Given this list of marker genes RAB11FIP3, RAB11FIP1, IL1B, C1QTNF3, RAB11FIP5, PPARG, HCAR2, here is a description of the gene set: Any process that modulates the frequency, rate or extent of the regulated release of adiponectin from a cell. species: Homo sapiens Human Gene Set: GOBP_REGULATION_OF_ADIPONECTIN_SECRETION